Given this list of marker genes IGF2R, ZDHHC17, CPEB3, NEDD4L, IRX4, PPP1R14C, ADGRL3, PCDH10, STK39, PANK1, RABGAP1L, ATP2A2, RBFOX1, ANO4, CHD9, ESRRG, CDH13, SATB2, GJA1, HSPD1, BCL2L11, TMEFF1, DNAAF9, RNF139, SMIM36, here is a description of the gene set: from publication Ikeda S, He A, Kong SW, Lu J, Bejar R, Bodyak N, Lee KH, Ma Q, Kang PM, Golub TR, Pu WT (PMID 19188439) Genes down-regulated in hypertrophic hearts (due to expression of constitutively active form of PPP3CA) and predicted to be targets of miR-30 microRNA. Human Gene Set: IKEDA_MIR30_TARGETS_DN studied in species Mus musculus Calcium signaling is a central regulator of cardiomyocyte growth and function. Calmodulin is a critical mediator of calcium signals. Because the amount of calmodulin within cardiomyocytes is limiting, the precise control of calmodulin expression is important for the regulation of calcium signaling. In this study, we show for the first time that calmodulin levels are regulated posttranscriptionally in heart failure. The cardiomyocyte-restricted microRNA miR-1 inhibited the translation of calmodulin-encoding mRNAs via highly conserved target sites within their 3' untranslated regions. In keeping with its effect on calmodulin expression, miR-1 downregulated calcium-calmodulin signaling through calcineurin to NFAT. miR-1 also negatively regulated the expression of Mef2a and Gata4, key transcription factors that mediate calcium-dependent changes in gene expression. Consistent with the downregulation of these hypertrophy-associated genes, miR-1 attenuated cardiomyocyte hypertrophy in cultured neonatal rat cardiomyocytes and in the intact adult heart. Our data indicate that miR-1 regulates cardiomyocyte growth responses by negatively regulating the calcium signaling components calmodulin, Mef2a, and Gata4.